The following is a description of a gene set: studied in species Mus musculus Catalysis of the reaction: dolichyl phosphate D-mannose + protein = dolichyl phosphate + O-D-mannosylprotein. Mouse Gene Set: GOMF_DOLICHYL_PHOSPHATE_MANNOSE_PROTEIN_MANNOSYLTRANSFERASE_ACTIVITY, and this is the list of marker genes: Tmtc4, Tmtc1, Tmtc3, Pomt1, Dpm1, Pomt2, Tmtc2, Tmem260